The following is a description of a gene set: part of: FGFR2 ligand binding and activation Reactome Pathway: FGFR2c ligand binding and activation species: Mus musculus This event has been computationally inferred from an event that has been demonstrated in another species.<p>The inference is based on the homology mapping from PANTHER. Briefly, reactions for which all involved PhysicalEntities (in input, output and catalyst) have a mapped orthologue/paralogue (for complexes at least 75% of components must have a mapping) are inferred to the other species. electronically inferred by orthology from the curated human pathway, and this is the list of marker genes: Fgf6, Fgf17 (NCBI Gene Id 14171), Fgf16 (NCBI Gene Id 80903), Fgf23, Fgf20, Fgf2, Fgf1, Fgf5, Fgf8, Fgf4